Given this list of marker genes Eci2, Eci1, Eci3, Echs1, Ehhadh, here is a description of the gene set: studied in species Mus musculus Catalysis of the reactions: a (3Z)-enoyl-CoA = a 4-saturated (2E)-enoyl-CoA or a (3E)-enoyl-CoA = a 4-saturated (2E)-enoyl-CoA. Mouse Gene Set: GOMF_DELTA_3_DELTA_2_ENOYL_COA_ISOMERASE_ACTIVITY